Given this list of marker genes Hpgds, Sirt2, Apoc2l, Degs1, Anxa1 (annexin A1), Alox5, Dcaf5, Agt, Nr1h2, Alox15, Acsm2, Asah2, Slc45a3, Ptgs1, Erlin2, Acsl4, Avp, Pnliprp2, Edn2, Abhd2, Cbr4, Lipg, Prkaa2, Ubr4, Fa2h, Htd2, Ptges3-ps, Gstm7, Ptges2, Acaa1a, Gstm2, Elovl2, Prkaa1, Hacd2, Daglb, Acadvl, Hsd17b4, Ndufab1, Prkab1, Scd3, Tbxas1, Gstp2, Hsd17b8 (NCBI Gene Id 14979), Acaa1b, Srebf1, Acsbg2 (acyl-CoA synthetase bubblegum family member 2), Pla2g4a, Acsbg3, Pdk4, Gstp1, Kat2b, Acsl1, Pnlip, Fads2b, Scd4, Klhl25, Aloxe3, Hsd17b12, Ltc4s, Fads2, Plp1, Hnf4a, Acsm3, Gstm3, Thnsl2, Gstm6, Acsm4 (NCBI Gene Id 233801), Gstm4, Sphk1, Acox1, Pla2g4f, Cd74, Scd1, Tecrl, Eif6, Lias, Mcat, Mlxipl, Ceacam1, Mif, Fabp5 (NCBI Gene Id 16592), Acsm5, Brca1, Pecr, Acot7, Mgll, Trib3, Prkag2, Elovl7, Fads6, Abhd3, Pla2g10, Pla2g3 (phospholipase A2, group III), Prkag3, Avpr1a, Scap, Myo5a (NCBI Gene Id 57374), Pnliprp1, Ehhadh, Sco1 (NCBI Gene Id 67104), Wdtc1, Prxl2b, Scp2, Apoc3, Cthrc1, Acacb, Tmem135, Elovl3, Insig2, Gip, Ptgs2, Abcd1, Fasn, Elovl6, Gstp-ps, Acaca, Hacd4, Abcd2, Rgn, Alox12b, Pibf1, Abcd3, Acsbg1, Mid1ip1, Fads3, Hnf1a, Nr1h3, Acss1, Lpgat1, Oxsm, Erlin1, Acsf3, Qki, Ptges, Pla2g2a, Olah, Sirt1, Insig1, Acadl, Prkag1, Mlycd, Cyp7a1, Apoc2, Edn1, Decr2, Ptgds, Ptgis, Hacd3, Gstp3, Apoa5 (NCBI Gene Id 66113), Acot8, Apoa4, Lpl, Apoc1, Alox8, Ceacam2, Tecr, Elovl4, Pnpla8, Alox12, Acsl3, Abhd1, Acss2, Gstm1 (NCBI Gene Id 14862), Elovl5, Lipc, Elovl1, Acsm1, Il1b, Hacd1, Mecr, Mapk9, Fads1, Prkab2, Pla2g1b, Ptges3, Acly, Scd2, here is a description of the gene set: studied in species Mus musculus The chemical reactions and pathways resulting in the formation of a fatty acid, any of the aliphatic monocarboxylic acids that can be liberated by hydrolysis from naturally occurring fats and oils. Fatty acids are predominantly straight-chain acids of 4 to 24 carbon atoms, which may be saturated or unsaturated; branched fatty acids and hydroxy fatty acids also occur, and very long chain acids of over 30 carbons are found in waxes. Mouse Gene Set: GOBP_FATTY_ACID_BIOSYNTHETIC_PROCESS